Given this list of marker genes Ankfy1, Vps4a (vacuolar protein sorting 4A), Rufy1, Vps8 (NCBI Gene Id 209018), Sphk1, Tgfbrap1, Vps41, Rab4b, Vps11, Vps39, Samd9l, Rab14, here is a description of the gene set: Mouse Gene Set: GOBP_ENDOSOMAL_VESICLE_FUSION species: Mus musculus The homotypic fusion of endocytic vesicles to form or add to an early endosome.